Given this list of marker genes KCNQ1 (potassium voltage-gated channel subfamily Q member 1), KCNE2, AKAP9, KCNE1, KCNE5, KCNH2, KCNE3, KCNE4, KCNA5, here is a description of the gene set: part of: Cardiac conduction Reactome Pathway: Phase 3 - rapid repolarisation studied in species Homo sapiens In phase 3 (the "rapid repolarisation" phase), the L-type Ca2+ channels close, while the slow delayed rectifier (I<sub>Ks</sub>) K+ channels remain open as more K+ leak channels open. This ensures a net outward positive current, corresponding to negative change in membrane potential, thus allowing more types of K+ channels to open. These are primarily the rapid delayed rectifier K+ channels (I<sub>Kr</sub>) and the inwardly rectifying K+ current, I<sub>K1</sub> (Kir). This net outward, positive current (equal to loss of positive charge from the cell) causes the cell to repolarize. The primary delayed rectifier K+ currents (I<sub>Ks</sub> and I<sub>Kr</sub>) are generated by K+ efflux mediated by potassium voltage-gated channel subfamily KQT member 1 (KCNQ1 aka Kv7.1) and potassium voltage-gated channel subfamily H member 2 (KCNH2 aka HERG) channels respectively (Park & Fishman 2011, Grant 2009). Specific to the atria, an ultra-rapidly activating delayed rectifier outward K+ current (I<sub>Kur</sub>) generated primarily by potassium voltage-gated channel subfamily A member 5 (KCNA5) helps to repolarize atrial cells.